Given this list of marker genes Cobl, Arpc5 (NCBI Gene Id 67771), Lcp1 (lymphocyte cytosolic protein 1), Espn (NCBI Gene Id 56226), Spire2, Carmil1, Pls1, Carmil2 (capping protein regulator and myosin 1 linker 2), Actn1, Spire1, Pls3, here is a description of the gene set: Mouse Gene Set: GOBP_ACTIN_FILAMENT_NETWORK_FORMATION The assembly of a network of actin filaments; actin filaments on different axes and with differing orientations are crosslinked together to form a mesh of filaments. studied in species Mus musculus